Given this list of marker genes Gm35048, Gtpbp6, Dek, Adpgk, Zc3h11a, Igf2bp1, Ube2q1, Rsad1, Wdr1, Snord110, Pcif1, Coch, E030030I06Rik, Camkk2, Utp18, Nfyc, Cln3, Alg3, Pkn2, Iqcb1, 1810062O18Rik, Avpi1, Snora21, Nkiras1, Ppp1r2, Scamp5, Tsc22d1, Snord58b, Tyw5, Spc25, Srsf2, 2700049A03Rik, Phf14, Slc30a9, Tbl1xr1, I830134H01Rik, Wdr77, Proser1, Hira, Pdxdc1, Orc5, Gtf3c3, Senp8, Gli2, Spink10, Srp68, Flvcr1, Dot1l, Mcm7, Macroh2a1, Baz2b, Smchd1, Cwc27, Hmga1, Dennd6b, Dpysl2, Lsm14b, Memo1, Rpl7, Gm11613, Eif5, Lmna, Srsf5, Morf4l1, Keap1, Mettl27, Nid2, Mmgt2, Vdac2, H3c3, 5730522E02Rik, Fnbp4 (formin binding protein 4), Cenpo, Nup98, Brf1, Parg, Ptpn21, Yod1, Lrrc58, Tpt1, Tgif1, Zcwpw2, Gm13162, Tjp1, Immt, 2310010J17Rik, Lin28a, Ccng1, Akap11, 4933431K14Rik, Srsf4, Rabep1, Gldc, Hapstr1, Wdr4, Tmprss12, Bnip1, AA474408, Rmi2, Rybp, Arnt (NCBI Gene Id 51910), Thap1, Fam13b, Snord15a, Usp53, Mrpl40, Cspp1, Pmpcb, Snora7a, Zfp36, Sgo1, Krit1, Hnrnph1, Ssc4d, Eif1, Camk2d, Tnpo2, Slc25a3, Zfand4 (zinc finger, AN1-type domain 4), Adprs, Slc6a16, Sf3b1, Zfp91, Ezr, Anapc13, Mthfd2l, Msantd5l, Xbp1, Ppm1d, Snx13, Btbd2, Bscl2, Cip2a, Sco2, Josd1, Ppan, Lsm14a, Mov10, 2010110E17Rik, Mtf2, Otud4, Ddb1, Platr4, Marchf8, Dynlt4, Zfp523, Tmem39b, 4931406C07Rik, Tnfsf13os, Capzb, Pdcl, Oaz1, C330002G04Rik, Pum2, Topbp1, Map3k3, Rbpms2 (RNA binding protein with multiple splicing 2), Rfx7, Rab11fip2, Jpx, 2500004C02Rik, Septin1, Pds5a, Ctbp2, Cc2d1b, 4931414P19Rik, Fubp3, Ppig, Pelp1, Dgcr2, Zbtb2, Enc1, Hk2, Mroh8, Mylpf, Gm13067, Ibtk, Pmf1, Rb1cc1, Fscn1, Ston2, Papola, Cdk12, D5Ertd579e, Syncrip, Gm24044, Lsm12, Gdi1, Prmt3, Ing4, Sox2, Dclk2, Cdk4, Poglut1 (protein O-glucosyltransferase 1), Maip1, Pigq, Dync2i2, Hnrnpa2b1, Ercc6l2, Fgfr2, Tcf12, B230217O12Rik, Dlg1, Smarcd1, Otx2, Csnk1d, Shisa7, Ryk, Atp6v1h, Mettl1, Zfp871, Rpl13a, Ebag9, Tanc1, Gm29642, Rpl3, Zfp689, Ndufs7, Mrpl39, Prpf19, Kctd20, N4bp2os, Polr2m (polymerase (RNA) II (DNA directed) polypeptide M), Spred3, Mrpl11, Gm5447 (predicted gene 5447), Ddx17, Atp6v0a4, Lyrm2, Mir3091, Nr2c2, Gm15489, Mir7668, Med1, Gm5464, Mrpl18, Ap1g1, Slc37a3, Ccdc57, Crip1 (NCBI Gene Id 12925), Mir148a, Hus1, Zfp131, Picalm, 4930592C13Rik, Orc4, Ino80b, Klf6, Phf3, Ppp2r3c, Fnbp1l, Psat1, Nop56 (NOP56 ribonucleoprotein), Ninj1, Gm4219, Appbp2os, 1810009A15Rik, Sfmbt1, Snx5, Timm44 (translocase of inner mitochondrial membrane 44), Ahr (NCBI Gene Id 193333), Bcas2, Ssrp1, Zfp326, Cks2, Macf1, Ppp2r5a, Erg28, Flicr, Akap12, Ttc28, Pola1, Kctd6, Gm25744, Gm15545, Ints5, St7, Ociad1, Zfp451, Kif20b, Psmb1, Arid4a, Brsk1, Mettl15, Slc39a9, Xkr6, Cul3, Gtpbp10, Mrpl3, Samm50, 1110020A21Rik, Ppp1r9a, Sephs1, Ints14, Atp5mc3, Dbf4, Zc3hav1l, Pdgfc, Zfp24, Sbf2, Cops5, Irs2, Dnai7, Zfp687, Son, Cbx3, Zfp27, Rab10os, Npm3-ps1, Malat1, Ap4m1, Kmt5a, Ino80, Tbck, Senp3, Nudcd2, Rpl21, Rxylt1, Mfsd11, Inhca, Tmem79, Rac1, Rpl15, Mxd3, 1700096K18Rik, Lrrc75a, Zfp652os, Snora16a, Sik3 (SIK family kinase 3), Sdc4, Gm2093, Hp1bp3, 4632404H12Rik, Rnf182, Uqcrh, Cbfa2t2, Slc25a36, 1110038B12Rik, Rab11b, Cog5, Gm12522, Sp1, Gm13620, Hmmr, Hbp1 (NCBI Gene Id 77235), Cyth2, 1110004F10Rik, Timm9, Gdi2, Zfp280b, Caprin1, Hmgcr, Ptov1, Patz1, Qrsl1, Dbil5, Wdfy1, Gm26562, Btbd19, Atp1b1, Hnrnpd, Pfkfb3, Nras, Cdc42bpa, Sppl3, Snord43, Pgap2, Itsn2, Gm17115, Copa, H2ax, Snhg12, Rab30, Adam17, Acsf3, Rpn2, Rnh1, H3c2, Xpo1, Oxsm, Zbed6, Srp19, 1700019D03Rik, Rnf145, Slc43a2, N4bp2, Rps5, Mbd5, Zc3h3, Smg5, Pole4, Jarid2, Rtn4ip1, Znrf1, Jade2, Mme, Nagpa, Parn, Stag1, Msl1, G2e3, Ttll5, Nrip1, Srek1ip1, Snora44, Rps27l, Bcl2l1, Dsg2, Gm11592, Zfp280d, Gm11423, Ngly1, Usf2, Bcl7b, Zfp367, 4930481B07Rik (RIKEN cDNA 4930481B07 gene), Ugp2, Atrx, Mir7666, Gm7467, Mettl8, Gm12743, Trrap, Rnf38, Prpf38b, Zbtb20, Eef1akmt3, Atpaf1, Eif5a, Prdx1, P2rx3, Rnf6, Msh6 (mutS homolog 6), Gm13445, Marchf7, Ankib1, Wwc2, Src, Bptf, Ube2e1, Cbfb, Nup58, Osbpl1a, Naa16 (NCBI Gene Id 66897), Gm26590, Steap2, Zc3h4, Golga3, Fgf20, Anapc11, 4732440D04Rik, Reep3, Gphn, Casd1, Cic, Pbrm1, Psrc1, Lap3, Fbxo21, Ptprk, Suv39h2, H2bc3, Amdhd2, Aamdc, Ggnbp2, Wdr41, Aimp1, Ptp4a1, Gm26704, Pias3, Pafah1b1, Zfp865, Naa15, Enoph1, Ece2, Pccb, Cul1, Adrm1, 4930509E16Rik, 4731419I09Rik, Penk, Zbtb41, Gm15927, 4930519P11Rik, Klhl9, Ranbp17, Pprc1, Rpl10a, Agpat4, Rpl30, Arhgef12, Aspscr1, Atp5po, Ppp1r3f, Fignl1, Mtmr2, Csde1, Rbbp4, Ankrd12, Zc3h7a, Etv1, Srd5a3, Prrg4, Fzd6, Ppm1l, Rictor, Gm23301, Gpbp1l1, Rps3, Champ1, Pnrc1, Gm10138, Bop1, Thap7, Mtg1, Il6st, B3gnt7, 6030443J06Rik, Snora26 (NCBI Gene Id 100313943), Hsp90ab1, Mbtd1, Klf2, Tpd52, Zranb2, Tlnrd1, Ran, Dyrk1b, Npepps, Nubp1, Map4k4, Sypl1, Mkln1os, Tcf3, Dph6, Prorp, Trdmt1 (tRNA aspartic acid methyltransferase 1), Vegfb, Arid1a, Moap1, Cep63, Mark2, Hsp90aa1, Nhlrc3, Ampd2, Slain2, Zfp619, Aars2, Mrpl21, Slmap, Gng5 (G protein subunit gamma 5), Ccdc43, Ndufab1, Klhl28, Eaf2, Ggn, Trp53inp1, 2900009J06Rik (NCBI Gene Id 72887), 4933406C10Rik, Notch2, Ncoa5, Hnrnpdl, Adnp, Rsf1os2, Gm15247, Ubald2 (UBA-like domain containing 2), Eif2a, Myl4, Daxx, Med13, Mpv17l, Lyset, 1700102P08Rik, Zmym4, Ythdc1, Flywch1, H3f3a, Tia1, Opa1, Mrps5, 4930432B10Rik, Atf1, Ywhaz, Marchf6, Azi2, Srsf11, Tor1aip1, Myo10, B4galt7, Dpy30, Chka, Ezh2, Ndrg1, Mir8120, Gm5106, Rps19, Yy1, Zfp936, Nek7, Ccl25, Rpl19, Tnrc18, Gm17344, Wtap, Eddm13, Haus6, Cdca7, Gm16253, Lactb2, 1700003G18Rik, Cpsf1, Pradc1, Mir1894 (microRNA 1894), Slc16a6, Cnot10, Chd8, Zbtb8os (zinc finger and BTB domain containing 8 opposite strand), Kpna2, Rif1, 1110059E24Rik, Cul4b, Ctcf, Nek2, Tent4a, Plekhm3, Ubtf, Sntb2, Ptges3, Pals2, Pura, Clns1a, Atp5pb, Zfp335os, Gm4285, Socs2, Resf1, Thap2, Gemin2, Fem1b, Mrpl48, Zfp661, Pfkfb2, Tor1aip2, Hdgfl3, Kmt2a, Sh2b3, Cog4, Acaca, 2310014F06Rik, Ctsa, 3110056K07Rik, Gm15787, Pfn4, Cibar1, Exoc2, Pef1, Gm12101, here is a description of the gene set: Mouse Gene Set: PWWP2B_TARGET_GENES from publication Yevshin I, Sharipov R, Kolmykov S, Kondrakhin Y, Kolpakov F (PMID 30445619) species: Mus musculus